Given this list of marker genes Hdac6, Atxn3, Stub1, Vcp, Dnajb14, Derl1, F12, Clu, Klhl15, Dnajb12, Ubr5, Akirin2, Ube2w (NCBI Gene Id 66799), Rnf126, Dnajc18, Ubr4, Cul3, Sdf2l1, Cav1, Ufd1, here is a description of the gene set: Any process that results in a change in state or activity of a cell or an organism (in terms of movement, secretion, enzyme production, gene expression, etc.) as a result of a misfolded protein stimulus. Mouse Gene Set: GOBP_RESPONSE_TO_MISFOLDED_PROTEIN species: Mus musculus